The following is a description of a gene set: The multiplication or reproduction of mammary gland branch epithelial cells, resulting in the elongation of the branch. The mammary gland branch differs from the bud in that it is not the initial curved portion of the outgrowth. species: Homo sapiens Human Gene Set: GOBP_EPITHELIAL_CELL_PROLIFERATION_INVOLVED_IN_MAMMARY_GLAND_DUCT_ELONGATION, and this is the list of marker genes: TFAP2C, ESR1, AREG, MED1, WNT5A